The following is a description of a gene set: Any process that decreases the rate, frequency, or extent of a response to cytokine stimulus. Human Gene Set: GOBP_NEGATIVE_REGULATION_OF_RESPONSE_TO_CYTOKINE_STIMULUS studied in species Homo sapiens, and this is the list of marker genes: PYDC2, MIR98, TREM2, YTHDF2, CNOT7, RNF113A, NR1H4, IL6ST, ZNF675, MIR20A, NR1H2, TLE5, OTOP1, USP25, IL6, CARD8, MIR29B1, OTUD4, MIRLET7C, TANK, F2RL1, MIR26A1, SH2B3, MIR27B (NCBI Gene Id 407019), PELI3, SMIM30, IL36RN, DCST1, ARG1, IL1RN, PXDN, MAPK7, NOL3, PALM3, IL1R2, PTPRC, RFFL, DICER1, MIR125B1, TNFRSF11B, PYDC1, GPS2, GAS6, PPP2CB, MIR21, TAX1BP1, RABGEF1, MIR101-1, MIR135A1, MIRLET7E, METTL3, MAP2K5, USP18, PPARG, CARD16, GSTP1, TRAIP, PADI2, PIAS4, GIGYF2, DNAJA3, PTPN2, ROBO1, CACTIN (NCBI Gene Id 58536), ANXA4, MIR125A, OAS3, ADAR, CCL5, CAV1, SIGIRR, CISH, MMP12 (matrix metallopeptidase 12), STAT2, MIR152 (NCBI Gene Id 406943), MIR27A, MUL1, CCDC3, ADIPOQ, APOA1, MIR138-1, NAIP, YTHDF3, PARP14, SLIT2, MIRLET7A1, ISG15, IRAK3, EIF4E2, STAP1, MIR24-1, BIRC7, SAMHD1, MIR130A, MIR146A, H2BC11, MIR99A, NLRP2B, CYLD, SLIT3, ECM1, CLDN18, NR1H3, XIAP, MIR520C, TREX1, TTLL12, NLRC5, KLF4, OAS1